The following is a description of a gene set: Phosphorylated PPARGC1A (PGC-1alpha) does not bind DNA directly but instead interacts with other transcription factors, notably NRF1 and NRF2 (via HCF1). NRF1 and NRF2 together with PPARGC1A activate the transcription of nuclear-encoded, mitochondrially targeted proteins such as TFB2M, TFB1M, and TFAM. PGC-1beta and PPRC appear to act similarly to PGC-1alpha but have not been as well studied. Transcription of PPARGC1A itself is upregulated by CREB1 (in response to calcium), MEF2C/D, ATF2, and PPARGC1A. Transcription of PPARGC1A is repressed by NR1D1 (REV-ERBA). species: Homo sapiens Reactome Pathway: Transcriptional activation of mitochondrial biogenesis part of: Mitochondrial biogenesis, and this is the list of marker genes: ACSS2, MTERF1, IDH2, PERM1, CAMK4, SOD2, NCOA6, GLUD2, HDAC3, MEF2C, PPARGC1A, MEF2D (myocyte enhancer factor 2D), ATP5F1B, CRTC3, NCOR1, POLG2, CREB1, GABPB1, SIRT5, TWNK, ATF2, NRF1, NR1D1, SSBP1, TFB1M, GABPA (GA binding protein transcription factor subunit alpha), TBL1X, PPRC1 (NCBI Gene Id 23082, PPARG related coactivator 1), HELZ2, SMARCD3, HCFC1, NCOA1, SIRT3, CRTC1, NCOA2, CARM1, GLUD1, CRTC2, ESRRA, CALM1, ALAS1, MED1, RXRA, SIRT4, CREBBP, POLRMT, TFB2M, TGS1, PPARGC1B, PPARA, CYCS, TBL1XR1 (NCBI Gene Id 81612), TFAM, CHD9